The following is a description of a gene set: Any process that results in a change in state or activity of a cell or an organism (in terms of movement, secretion, enzyme production, gene expression, etc.) as a result of a stimulus from a xenobiotic, a compound foreign to the organism exposed to it. It may be synthesized by another organism (like ampicilin) or it can be a synthetic chemical. Mouse Gene Set: GOBP_RESPONSE_TO_XENOBIOTIC_STIMULUS species: Mus musculus, and this is the list of marker genes: Card9, Col6a1, Mcpt1, Bmyc, Bdnf, Mat2a, Fgf8, Emx2, Fmo4, Cyp2t4, Gas6, Gpr39, Nfe2l2, Mir7116, Ppp1r9b, Dpyd, Cd38, Sult2a5, Slc1a2, Gstp3, Abcb1a, Htr2a, Acsl1, Kdr (kinase insert domain protein receptor), Cdkn2a, Cyp2d34, Igkj1, Nr1i2, Atg5, Cyp2c68, Gpx1, Cyp2c65, Kcnj11, Emx1, Slitrk5, Mcm7, Sult2a2, Nfkbiz, Dmd, Drd2, Traf3ip2, Tfrc, Ntrk1, Lck, Xrcc1, Becn1, Nppc, Gna12, Gstm5, Slc22a12, Aacs, Gsta3, Slco1a6, Abcg5, Lipa, Atp1a3, Cftr, Cpt1a, Aox3, Bche, Fos, Uts2, Abcd3, Cyp2j6, Rpp21, Rb1, Ube2b, Tlr3, Itgb3, Hmbs, Acaa1a, Acer2, Trp53i13, Srd5a1, Umps, Sox10, Fzd1, Lhcgr, Terf1, Gnpat, Cyp2a12, Cyp1a2, Adipor2, Maob, Wnk4, Mmp2 (NCBI Gene Id 17390), Nr1h4, Pfas, Gsta13, Cyp2j8, Nkx6-1, Gsta1, Rap1a, Fmo5, Th, Slc6a3, Agtr1b (NCBI Gene Id 11608), Ifng, Cyp46a1, Guk1, Gsta5, Ccl4, Ppox, Gstm7, Abat, Cyp2b23, N6amt1 (N-6 adenine-specific DNA methyltransferase 1 (putative)), Serpina7, Defa3, Kcnh2, Adipoq, Mmp9, Grm2, Srp68, Agpat2, Cdkn1b, Aip, Rest, Tigar, Fmo2, Ppp1r14a, Slc6a2, Ptgs2, Ppp1r12a, Cyp2g1, Mmp7, Cyp2b19, Acacb, Cyp2j9, Slc18a2, Cyp26b1, Cyp2c37, Adcy1, Drd3, Map1b, Smad1, Hsd11b2, Pemt (phosphatidylethanolamine N-methyltransferase), Slc6a4, Nos1, Hmgcs2, Cyp2e1, Adm, Il10, Nfatc2, Vav3, Map2k6, Pam, Gstm6, Cyp2b13, Aldh2, Fbp1, Abcb1b, Tent4a, Cyp1a1, Rhbdd3, Shank2, Igfbp2, Oxsr1 (oxidative-stress responsive 1), Rad51, Cyp2d26, Smpd1, Abcc9, Pcsk1, Nceh1, Tgfbr2, Nos2, Cyp2w1, Add3, Sst, Fech, Calr, Aox4, Sult2a1, Slc1a1, Pde4a, Abca1, Gclm, Gstm3, Phb1, Ggh, Htr1b, Cad, Edn1, Tspo, Lyn, Nkx3-1 (NK3 homeobox 1), Cyp2c55, Prnp, Lrp8, C130074G19Rik, Ankrd1, Gabrb3, Ugt2b1, Abcc1, Tfap2b, Lta, Nckap1l, Uchl1, Gpld1, Comt, Rps6kb1, Fzd3, Sult1a1, Cyp2c70, Sult2a7, Aim2, Acaa1b, Cyp2d11, Cd69, Cyp3a11, Srr, Ywhaz, Cyp2c67, Cyp2c38, Gabrg3, Sult2a8, Top1, Cers1, Igf2, Cyp2u1, Rap2a (NCBI Gene Id 76108), Scgb1a1, Gsto2, Cyp2j11, Tgfb1, Lcn2, Rhoa, Cyp2b9, Gstt1, Cyp2j5, Cdh13, Chrna3, Nnmt, Otc, Gsta2, mt-Nd1, Gk, Ehmt2, Cyp2c50, Ptpn5, Recql5, Cbr1b, Cyp2a22, Mdm2, Ahr, Cyp2c54, Blm, Gstm1 (glutathione S-transferase, mu 1), Atp1a1, Gnas, Asic2, Cpb2, Sfrp1, Ass1, Cyp3a41b, Cyp2d10, Lox, Abcg8, Bloc1s3, Rela, Mas1, Cyp2d22, Grin2a, Aldh1a1, Vegfc, Cyp2j7, Pax4, Ugt1a6b, Cyp2b10, Gstp-ps, Cyp2f2, Prickle1, Cat, Cyp26a1, Scn11a, Cyp2c66, Kcnq2, Slc12a5, Xpc, Foxo3, Slc10a4, Cyp2c23, Apobec1, Cyp2r1, Itga2, Cyp2d9, Sfrp2 (NCBI Gene Id 99743), Cyp2c69, Sult2a6, Tjp1, Aox1 (NCBI Gene Id 98286), Abl1, Tnf, Hnf4a, Ahrr, Mgst1, Cybb, Ogg1, Rph3al, Uqcrc2, Akr1c20, Casp3, Tcf3, Egfr, Aldh3a1, Cyp2c40, Sult1c1, Ace, Jun, Ei24, Rptor, Ss18, Akr1c13, Cyp3a41a, Npc1, Eng, Car9, Slamf8, Ret, Hdac5, Ptk2b, Sult2a3, Snca, Sult1b1, Myo6, Gstm4, Vkorc1, Rbm22, Tyms, Adra1a, Slc1a3, Fmo1, Nqo1, Cyp2a5, Htr2c, Rad54l, Kcnq3, Mef2c, Crhbp, Ccl2, Rogdi, Abcb11, Cyp27b1, Fosb, Ren1, Defa2 (defensin, alpha, 2), Gria1, Fmo3, Errfi1 (NCBI Gene Id 74155), Hadha, Cntnap2, Ppm1e, Adora2a, Rap1b, Pms2, Myc, Usp47, Tbxa2r, Dgcr2, Cdk1, Fancb, Gstm2, Gata6, Kcnc1, Cyp2c39, Star, Cyp2d12, Cdh3, Trpa1, Cryz, Chrna7, Tnfrsf11b, Slco1b2, Cdkn1a, Slc10a1, mt-Cytb, Creb1, Cyp3a16, Grin1, Srebf1, Gsto1, E2f1, Htr2b (5-hydroxytryptamine (serotonin) receptor 2B), Src, Slc26a5, Akap5, Lpo, Ccnd1, Cyp2a4, Col1a1, Cyp1b1, Arnt2, Npas2, Ppm1f, Pnp, Txn2, Mylk, Umod, Ctnnb1, Rnf149, Akr1c12, Hdac4, Gpr52, Hsp90aa1, Dnmt1, Pdx1, Actc1, Pax6, Dusp6, Slc6a11, Gata3, Dpep1, Cdk4, Casp1 (caspase 1), Hspa8, Rad54b, Gip, Prkaa2, Chek2, Trp53, Itga3, Fosl1, Pon3, Kcnk3, Crh, Il1b, Scnn1b, Slc19a1, Pde4b (NCBI Gene Id 97194), Adam17, Lyst (NCBI Gene Id 217998), Kcnj8, Plin2, Cyp2ab1, Ep300, Sod2, Bak1, Cps1, Serpine1, Gata4, Ptch1, Prkaa1, Ccno, Lct, As3mt, Xrcc5, Uchl1os, Prkcb, Crkl, Cbr1 (carbonyl reductase 1), Kcne2, Smtnl1, Crot, Alad, Aox2, Nudt15, Tpmt, Gsta4, Abcc2, P2rx7, Txnip, Ugt1a1, Gstp1, Sod1, Srd5a2, Cyp2c29, Kcnq1, Mapk9, Rora, Gstp2, Gclc, Sufu, Gad2, Blmh, Sult2a4, Fkrp, Xbp1, Ptprm, Uqcrfs1, Akr1c6, Cyp3a44 (cytochrome P450, family 3, subfamily a, polypeptide 44), Slco1a1, Atp4a, Hadh, Braf, Cyp2s1, Ccl3, Ccnt1, Oxtr, Rorc, Bcl2, Rasa1, Cyp2j12, Cyp2j13, Bloc1s6, Drd1, Dnmt3a, Pde3a, Fosl2, Ncam1, Ugt1a6a, Pcna, Pnp2